The following is a description of a gene set: Human Gene Set: MIR4448 from publication Chen Y, Wang X (PMID 31504780) Genes predicted to be targets of miRBase v22 microRNA hsa-miR-4448 in miRDB v6.0 with MirTarget v4 prediction scores > 80 (high confidence targets). studied in species Homo sapiens, and this is the list of marker genes: BRMS1L, ARID2, NRG1, GRID2, NFATC2, MRPL16, CCDC88A, AHRR, MTO1, GID4, ZBTB34, KATNBL1, RHOU, CASP4, GATA3, TMEM161A, CREBRF, CDH19, TBL1XR1, FAM177A1, EIF2AK1, NQO2, SRPK1, ZNF616 (zinc finger protein 616), FHOD3, ZNFX1, BRWD3, KIF3A, TPM3, PHF8, TMEM243, SLC31A1, CXXC4, PGAM5, WDFY2, PAN3, ENTPD4, PDE8B, UBL4A, TBR1, ZNF680, OPHN1 (NCBI Gene Id 4983), RNF4, CHD2, NFYC, BPTF (bromodomain PHD finger transcription factor), SOX7, EGLN1, SCN1A, LRRN1, ADAMTS6, SALL2, PITPNB, MAT1A, SLC7A1, PKIB, BBX, GABRA4, AFG1L, SCAF8, LDAH, HRH2, OSBPL6, MAP7, AGAP1, STX17